Given this list of marker genes MAPK14, IL2RA, EOMES, MAP2K3, HLA-DRA, IL1R1, RELB, LCK, IL2, FASLG, STAT4, GADD45G, HLX, CCR5, GZMA, SPHK2, CD3E, RIPK2, IL12RB2, STAT1, IL4, HLA-A, CCL4, RAB7A, STAT3, NFKB1, MAP2K6, IL12A, STAT5A, TBX21, IL2RB, CD8B, IL12B, CD4, STAT6, PPP3CA, CD3D, CD8A (CD8 subunit alpha), PPP3R1, GADD45B, IL18R1, IFNG (NCBI Gene Id 3458), CCL3, MTOR, TYK2, IL18 (interleukin 18), CD247, CD3G, B2M, SOCS1, JAK2, ATF2, GZMB, PPP3CB, IL18RAP, RELA, NOS2 (nitric oxide synthase 2), NFKB2, FOS, IL1B, IL12RB1, IL2RG, here is a description of the gene set: Human Gene Set: PID_IL12_2PATHWAY IL12-mediated signaling events species: Homo sapiens from publication Schaefer CF, Anthony K, Krupa S, Buchoff J, Day M, Hannay T, Buetow KH (PMID 18832364)